Given this list of marker genes SLC25A13, TAF13, CDH23, TBX3, AIP, KRAS, BMP15, CUL4B, PGM1, BNC1, TRMT10A, GLI2, LGR4, EXT2 (NCBI Gene Id 2132), CYB5A, INSR, POMC, SNORD116-1, ZBTB20, GLA, LZTR1, KISS1R, LEPR, ESR1, SNRPN, SMC3, DACT1, SPRED2, NIPBL, STAT5B, FLII, MRPS22, WT1, CISD2, BRCC3, WDR11, BRD4, G6PC1, GMNN, PROK2, CARS1, ZFX, MAP3K1, MT-TL1, FOXA2, HESX1, MSMO1, HBB, ENTPD1, SNORD115-1, WFS1, RPL10, GNRHR, NSMF, PHKA2, FGF17, SPIDR, RAF1, TCF12, PHKG2, CTNNB1 (catenin beta 1), PROKR2, IGFALS, MAP3K7, DHX37, SALL1, NDN, GATA4, CCDC141 (coiled-coil domain containing 141), RBM28, SOS1, CPE, OCA2, HROB, ROBO1, SOX10, HLA-DQB1, PHF21A, SMPD1, TRIP4, CBL, MRAS, RRM2B, LPIN2, CLCNKB, PTPN11, SRY, SEMA3E, SPTBN1, ALX4, ATM, SPRY4, GHSR, ZSWIM7, POLR3B, POLR3A, LMNA, PRDM13, NUP107, DIAPH1, VAMP7, POF1B, TBC1D20, PNPLA6, DUSP6, TAF6, TAC3, HLA-DQA1, MEN1, GNRH1, GHR, EIF5A, FGFR1, NRAS, RAB18, LHB, STAT3, CYP11A1, POLR3H (RNA polymerase III subunit H), FGD1, ZMPSTE24, RAD21, TACR3, PYGL, NR0B1, COL7A1, NR5A1, STUB1, MKRN3, PPP1R15B, PROP1, PUS1, POLR3GL, NPAP1, PHF6, CTNS, NDNF, SOS2, NLRP3, SOX11, SOX3, OTX2, NDP, GALT, POU1F1, VPS13B, TGFB1, NONO, IQSEC2, STAT1, MAGEL2, RAI1, FGF8, RRAS2, PTRH2, RAB3GAP1, NOTCH2, MSH4, USP9X, FLRT3, FSHB, POR, SLC29A3, RIT1, BRAF, HS6ST1, CYP17A1, SLC12A3, HERC2, MMP1 (matrix metallopeptidase 1), NF1, PWRN1, FAM111B, NHLH2, ZFPM2, CHD7, LHX4, WWOX, YARS2, SOX9, ANOS1, RAB3GAP2, DCC, DEAF1, SEMA3A, OCRL, CENPT, PCSK1, MT-ATP8, PWAR1, SCARB2, GPR161, ALDOA, EIF2S3, RASA2 (RAS p21 protein activator 2), CDON, DNM1L, HDAC8, BTK, SMC1A, FSHR, ATAD3A, PSMC3IP, ALMS1, AR, FEZF1, SLC37A4, RRAS, PEX10, IL17RD, GBA1, KISS1, here is a description of the gene set: Human Gene Set: HP_DELAYED_PUBERTY Passing the age when puberty normally occurs with no physical or hormonal signs of the onset of puberty. Delayed puberty species: Homo sapiens